Given this list of marker genes CDK1, CNEP1R1, LMNA (lamin A/C), PRKCB, LEMD2, CTDNEP1 (NCBI Gene Id 23399), TMPO, LEMD3, LPIN2, PRKCA, LPIN1, LPIN3, CCNB1, EMD, LMNB1, here is a description of the gene set: studied in species Homo sapiens The nuclear envelope breakdown in mitotic prophase involves depolymerization of lamin filaments, the main constituents of the nuclear lamina. The nuclear lamina is located at the nuclear face of the inner nuclear membrane and plays and important role in the structure and function of the nuclear envelope. Depolymerization of lamin filaments, which consist of lamin homodimers associated through electrostatic interactions in head-to-tail molecular strings, is triggered by phosphorylation of lamins. While CDK1 phosphorylates the N-termini of lamins, PKCs (PRKCA and PRKCB) phosphorylate the C-termini of lamins. PKCs are activated by lipid-mediated signaling, where lipins, activated by CTDNEP1:CNEP1R1 serine/threonine protein phosphatase complex, catalyze the formation of DAG. Reactome Pathway: Depolymerization of the Nuclear Lamina part of: Nuclear Envelope Breakdown